Given this list of marker genes Grm7, Cbarp, Ptk2b, Atp2b1, Camk2g, Ano9 (anoctamin 9), Hes1, Fasl, Slc24a1, Ank2, Ms4a1, Cxcl9, Ghitm, Stac2, Nipsnap2, Zfas1, C2cd6, Trim27, Plcb2, Nalf1 (NALCN channel auxiliary factor 1), Fgf14, Flna, Tgfb1, Asph, Rcvrn, Hspa2, Atp2b3, Lyn, Ramp2, Trpc2, Psen2, Gpr35, Trpc4, Itpr1, Ehd3, Xcr1, Ptger3, Letm2 (leucine zipper-EF-hand containing transmembrane protein 2), Ngf, Ptpn22, Ntsr1, Nalcn (NCBI Gene Id 338370), Jph2, Tmbim6, Trpm7, Tmco1, Sestd1, Ptpn6, Lilra5, Slc8a1, Trpc5, Cd84, Hap1, Pde4d, Homer3, Grin2a, Ddit3, Plpp4, Pln, Calhm1 (calcium homeostasis modulator 1), Atp13a4, Cacng7, Cachd1, Tmc1, Dbi, Hspa9, Cacna2d1, Hoxa3, Ccl21a, Crh, Cav1, Sumo1, Jph3, Bax, Grin3b, Gsto1, Cacng5, Gimap3, Tspan13, Htt, Hrh1, Stac, Tmem37, Oga, Ahnak, Crhr2, Epo (erythropoietin), Ace, F2, F2r, Calm1, Catsper3, Grin2c, Plcl1, Prnp (prion protein), Ramp1, F2rl3, Prkcb, Slc8b1, Cnga4, Ero1a, Lpar3, Cacnb3, Cxcr4 (C-X-C motif chemokine receptor 4), Creb3, Trpc7, Ccl19, Nfatc1, Usp2, Cxcl10, Bak1, Selenok, Dnm1l, Cacng6, Catsper4 (NCBI Gene Id 329954), Bhlha15, Grin3a, Adcyap1r1, Ccl21e, Ms4a2, Il13, Ppp3r2, Ahr, Calhm3, Ccr5, Capn3, Ccl5, Cacnb4, Ccl19-ps6, Nfatc3, Cacna1s, Trpm6, Drd2, Cacna1g, Ubash3b, Trdn, Cacnb2, Fkbp1a, Myb, Mettl21c, Tspan18, Ppp3ca, Cracr2a, Slc9a1, Grxcr1, Plcg2, Glp1r, Ccl21d (C-C motif chemokine ligand 21D), Orai1, Wfdc6a, Eppin, Cacng1, Gpr39, Gck, Cacng4, P2rx1, Cacna1f, Nalf2, Tmc2 (NCBI Gene Id 192140), Cdh23, Cyp27b1, Coro1a, Tmem165, Letm1, Gp5, Anxa6, Plch1, Lgals3, Cacng3, Ccr1l1, Ccl19-ps3, Ncs1, Plcb4, Htr2a, Tspo (translocator protein), Pdgfrb, Plcl2, Abl1, Akap5, Rgs4, Nos3, P2ry6, Cacna1b, Gp9, Gcg, Casq2, Diaph1, Oprd1, Cxcl11, Htr2b, Dspp, Pdgfb, Cacnb1, Psen1, Vmp1, Trpv1, Plp1, Cask (calcium/calmodulin dependent serine protein kinase), Pacsin3, Slc35g1 (NCBI Gene Id 240660), Dhrs7c, Cacna1e, Cacna1a, Slc25a25, Cacna2d4, Gp1bb, Casr, Hrc, Zmpste24, Cav3, Pkd2l1, P2rx5, Fyn, Ppp3cc, Mrln, Ccl8, Maip1, Ccn2, Gnb5, Cysltr1, Trpv6, Vdac1, Cacng2, Slc25a23, Stim2, Fmr1, Rem1, Bin1, Grin2d, G6pd2, Ccl21b, Trpm3, Ppp3cb, Adrb1, Gramd2a, P2ry12, Gas6, Cacna1i, Igf1, Ccl19-ps4, Lck (lymphocyte protein tyrosine kinase), Cnga3, Fbxo11, Calm3 (calmodulin 3), Stac3, Afg3l2 (NCBI Gene Id 69597), Trpm2 (NCBI Gene Id 97643), Itpripl1, Fcrl5, Gja1, Gimap5, Atp2a2, Spink1, Icam1, Cnga2, Cyba, Lhcgr, Ubqln1, Sln, P2rx7, Trpc3, Tmem38a, Plcz1, Ednrb, Plch2, Ptgs2, P2rx4, Itgb3, Prkce, P2rx3, Srl, Slc24a3, Plce1, Gjc2, Drd1 (NCBI Gene Id 77537), Cd4, Epm2a, Lime1 (Lck interacting transmembrane adaptor 1), Pkd1l3, Calhm2, Ctnnb1, P2rx2, Akt1, Adra1a, Grm6, Opa1, Prkd1, Tgfb2, Jsrp1, Plcg1, Hpca, Cacng8, Atp2c1, Itpr3, Cherp, Cemip, Cd19, Plcb1, Mylk, Camk2b, Kcnn4, Kcnj8, Panx1, Slc24a2, Bmp4, Vdr, Slc30a1, Rapgef3, Smdt1, Sec61a1, Rgs9, Stim1, Gnai2, Ccl3, Ffar1, Hcrt, Itpr2, Ryr3, Ppp3r1, Panx3, Homer1, Rhoa, Ccl19-ps5, Orai3, Htr2c, Gstm7 (glutathione S-transferase, mu 7), Pawr, Atp2b2, Best1 (bestrophin 1), Slc8a3, Ccl12, Mcub, Camk2d, Pkd2 (NCBI Gene Id 77380), Cxcr3, Slc24a5, Mcoln1, Jak3, Slc24a4, Atg5, Edn1, Aplnr, Inpp5k, Saraf, Il16, Scn11a, Catsper1, Micu1, Gpm6a, Atp1a2, Slc8a2, Chrna4, Trpv3, Cdk5, Micu2, G6pdx, Clec4b1, Chrna7, Aqp2, Orai2, Gnao1, Cx3cl1, Bdkrb1, Pkd1, Calcrl, Ibtk, Snca, Pml, Cxcl12, Cnga1, Smim6, Stc1, Cacna1d, Ednra, Grin1, Gja4, Agt, Sri, Tpcn1, Cacna2d3, Epb41 (NCBI Gene Id 52373), Mcoln2, Ccl21f, Ubr3, Serpine1, Plcb3, Dysf, Chd7, Ucn (NCBI Gene Id 22226), Atp2c2, Stc2, Nos1, Pkd1l1, Xcl1, Atp2a3, Cckar, Trpc1, Cacna2d2, Mcu, Ccl19-ps1, Ywhae, Mcur1, Atp2a1, P2rx6, Tpcn2, Efhb, Fkbp1b, Ccr1, Ryr1, Egf, Strit1, Trpv5, Spg11, Trpm4, Trpv4, Stimate, Mchr1, Trpa1, Micu3, Clca1, Trpm8 (transient receptor potential cation channel, subfamily M, member 8), Homer2, Adrb2, Asic1, 1810037I17Rik, Spg7, Bcl2, Trpc6, Bspry, Camk2a, Ramp3, Adora2a (NCBI Gene Id 11540), Cacna1h, Fgf2, Trpm1, Wnk3, Cldn16, Catsper2, Pik3cg, Tmem38b, Calm2, Tmx1, Cracr2b, Arrb2, Chrnb2, Gper1, Tlr9, Akap6, Ptprc, Ucp2, Drd4, Casq1, Atp1b1, Jph4, Gcm2, Myo5a, Selenon, Gp1ba, Nol3, Dmd (dystrophin, muscular dystrophy), Grin2b, Ano6, Npsr1, Agtr1a, Ryr2, Thy1, Trpv2, Cacna1c, Itgav, Pdpk1, Wfs1 (wolframin ER transmembrane glycoprotein), Wnt3a, Atp2b4, Isl1, Nppa (NCBI Gene Id 230899), here is a description of the gene set: Mouse Gene Set: GOBP_CALCIUM_ION_TRANSPORT studied in species Mus musculus The directed movement of calcium (Ca) ions into, out of or within a cell, or between cells, by means of some agent such as a transporter or pore.